The following is a description of a gene set: Human Gene Set: GSE30083_SP1_VS_SP4_THYMOCYTE_UP species: Homo sapiens Genes up-regulated in comparison of SP1 thymocytes versus SP4 thymocytes. from publication Teng F, Zhou Y, Jin R, Chen Y, Pei X, Liu Y, Dong J, Wang W, Pang X, Qian X, Chen WF, Zhang Y, Ge Q (PMID 22022412) After positive selection in the thymus, the newly generated single positive (SP) thymocytes are phenotypically and functionally immature and undergo apoptosis upon antigen stimulation. In the thymic medullary microenvironment, SP cells progressively acquire immunocompetence. Negative selection to remove autoreactive T cells also occur at this stage. We have defined four subsets of CD4 SP, namely, SP1, SP2, SP3, and SP4 that follow a functional maturation program and a sequential emergence during mouse ontogeny.We used microarray to detail the global programm of gene expression during the maturation of murine CD4 single positive thymocytes, and this is the list of marker genes: AKAP1, MAPK6, TRAF4, FKBP1A, UBTD1, RAB27B, SLC45A3, KLHDC4, COQ4, TUBB2B, CCHCR1, YIF1B (Yip1 interacting factor homolog B, membrane trafficking protein), MAPK11, ZNF711, CDC25A, LRRC42, HCN3, FJX1, BCL7A, EMILIN1, PLA2G12A, CBX2, ARMCX6, SLC35D3, NEDD4, SEMA7A, MARCKS, GHDC, EPHB6, EDARADD, KLF10, ZNF410, SLC27A1, RPL7L1 (NCBI Gene Id 285855), HIVEP3, DYNLT5, ABCC5, KIFC3, LAPTM4B, SMO, SYNE3, DPM1, SLC35B1, TNK2, HSD17B12, IRF2BP1 (interferon regulatory factor 2 binding protein 1), BYSL (NCBI Gene Id 705), GPRASP3 (NCBI Gene Id 80823), TUBA1A, CCSER1, PRR32, ST3GAL2, RRS1, IRAK1BP1 (NCBI Gene Id 80793), ARHGEF6, CTXN1, ATXN10, VILL, WDR4, GPS1, TCF7L2, PTDSS2, GABRB3, TPK1, RALB, CHL1, C1QTNF12, TDRKH, STARD3, AQP9, RBM19, MUC5B, SOST, HDAC3, TMEM132A, MYO6, YPEL2, ENTHD1, SLC25A47, CCT3, FLT4, CTNNBIP1, IFT81, EVI5L, TMEM120B, WDR70, ARHGEF17, XBP1, CD81, MCAM, LAMC1, PSD3, ILF3 (interleukin enhancer binding factor 3), PPP1R2P1, CCDC86, CRY1, GPC1, ABHD17C, BBS1, ANKRD45, HHAT, GOT1, GOLM2, RAPSN, NXN, ITM2A, WDR35, RRP1, AARS2, NCBP2, TSC22D1, ARF1, CYP2A6 (NCBI Gene Id 82212), MARCKSL1, CCDC157, GTF3C5, CNOT11, GPHN, GLYAT, TUBA4A, F13A1, DEDD, RBP7, DMWD, SCN1B, LCMT1, ZNF823, ANP32B (acidic nuclear phosphoprotein 32 family member B), PLA2G2A, UCHL1, PAK1, AGPAT4, LSS, HNRNPDL, ZNF22, BMF, CDADC1, QSER1, MEX3A, GET1, HS2ST1, DHCR24, UBE2E3, PPAN, L1TD1, CNN3, UBTD2, MTF2, AIFM1, UTP25, DDIAS, ENO2, PTOV1, LARP6, STRBP, CTDSPL, UPK1A, BLMH, PADI4, GPR153, SORD, TRIB1 (tribbles pseudokinase 1), MMP9, TMTC3, HACD1, CFAP69, LZTFL1, C5orf15, PLOD2, SLC30A4, SPRED1, SERPINI2, TSPAN6, REEP6 (NCBI Gene Id 92840), IFT57, ZCCHC12, ZNF821, CBLC, KCNMB2, ATXN7L2, PDZD11, ALDH7A1, ASB2 (ankyrin repeat and SOCS box containing 2), SMARCC1, PRPF19, REPIN1, SPATA6, LRP12, MBOAT2, PTPRS, SATB1, ACOT7, ZIK1, CBX1, RYR2, ETV5, CAPN10, SYTL2, CILK1, TSSC4